The following is a description of a gene set: Pathway Definition from KEGG: PRC1.1 -- (USP7+TRIM27) -- H2AK119+UB -> PRC2.2 studied in species Homo sapiens Human Gene Set: KEGG_MEDICUS_REFERENCE_ACTIVATION_OF_PRC2.2_BY_UBIQUITINATION_OF_H2AK119 Activation of PRC2.2 by ubiquitination of H2AK119. Pathway ID: N01586. Pathway type: Reference. Pathway class: nt06523 Epigenetic regulation by Polycomb complexes., and this is the list of marker genes: BCOR, H2AC1, TRIM27, EZH1, BCORL1, RING1, RYBP, KDM2B, YAF2, JARID2, PCGF1, UBB, EZH2, RBBP4, SKP1, USP7, H2AC4, EED, SUZ12, AEBP2, RBBP7, RNF2